Given this list of marker genes BARD1, DNAJC2, UIMC1, RNF169, CCDC38, USP15, BRCA1, TP53BP1, JARID2 (NCBI Gene Id 3720), here is a description of the gene set: studied in species Homo sapiens A histone reader that recognizes a histone bearing a ubiquinated lysine residue. Human Gene Set: GOMF_UBIQUITIN_MODIFIED_HISTONE_READER_ACTIVITY